The following is a description of a gene set: Little is known about the long-term consequences of overexpression of the human telomerase reverse transcriptase (hTERT) gene in T lymphocytes. To address this issue, we transduced polyclonal as well as clonally derived populations of naive and memory CD44 T cells from 2 healthy donors (aged 24 and 34 years) with retroviral vectors encoding green fluorescence protein (GFP) and hTERT (GFP-hTERT) or GFP alone. After transduction, cells were sorted on the basis of GFP expression and cultured in vitro until senescence. T cells transduced with hTERT exhibited high stable telomerase activity throughout the culture period. Relative to GFP controls, minor changes in overall gene expression were observed yet the proliferative lifespan of the hTERT-transduced populations was significantly increased and the rate of telomere loss was lower. Nevertheless, hTERT-transduced cells showed progressive telomere loss and had shorter telomeres at senescence than controls (2.3 +/- 0.3 kilobase versus 3.4 +/- 0.1 kb). Furthermore, a population of cells with 4N DNA consisting of binucleated cells with connected nuclei emerged in the hTERT-transduced cells prior to senescence. We conclude that overexpression of hTERT in CD4+ T cells provides a proliferative advantage independent of the average telomere length but does not prevent eventual genetic instability and replicative senescence. Human Gene Set: ROETH_TERT_TARGETS_DN Genes down-regulated in T lymphocytes overexpressing TERT off a retrovirus vector. studied in species Homo sapiens from publication Röth A, Baerlocher GM, Schertzer M, Chavez E, Dührsen U, Lansdorp PM (PMID 15741219), and this is the list of marker genes: CLEC2B, GZMK, KLRC1, SPTBN1, CRIM1, CCR2, CCR5, CCR1, CXCR6